The following is a description of a gene set: species: Mus musculus Mouse Gene Set: GOCC_LUMENAL_SIDE_OF_MEMBRANE Any side (leaflet) of a membrane that faces the lumen of an organelle., and this is the list of marker genes: Nucb1 (NCBI Gene Id 97355), Noa1, Kcnq1, Sppl2b, Ndufaf5, Dmd, Sppl2a, Sppl3, H2-T3, H2-Q7, H2-T23, H2-D1, Sppl2c, Coa8, H13, H2-K1, Pkd2, Aqp2, Canx, Dnajc19, H2-Q10, Ambp, Bdh1